The following is a description of a gene set: Any process that activates or increases the frequency, rate or extent of transcription elongation, the extension of an RNA molecule after transcription initiation and promoter clearance by the addition of ribonucleotides catalyzed by a DNA-dependent RNA polymerase. Human Gene Set: GOBP_POSITIVE_REGULATION_OF_DNA_TEMPLATED_TRANSCRIPTION_ELONGATION species: Homo sapiens, and this is the list of marker genes: MED11, MED17, CTNNB1, CDK13, MED1, NCBP1 (nuclear cap binding protein subunit 1), CDC73, MED25, CCNK, MED10, HMGN1, MED23, MED30, MED27, MED22, SUPT5H, MED7, MED9, BTBD18, MED26, ZMYND8, ELL3, SUPT4H1, GTF2F1, MED14, PPP1R10, TOX4, TCERG1, MED18, PARP1, MAP2K1, MED15, MED20, BRD4, LEO1, SUPT16H, MED28 (NCBI Gene Id 80306), MED6, LDB1, CCNT1, PWWP2B, MED31, MED8, KAT7, CCNT2, MED21, CDK9, PWWP2A, MED16, ELL2, MED4, ELL, EAPP, WDR82, MED29, CDK12, PPP1CA, SCAF8, MED24, NCBP2, ERCC6, MED19